Given this list of marker genes ADH1A, LGALS4, PPP5C, PPP2R5C, LPIN1, RTF1, BYSL, ICA1, COMT, RPL36AL, SPARC, SLC4A1, DNTTIP2, TOP1, SLC25A46, WT1, ERF, MSH3, RARRES2, DRD3, TAF4, PSKH1, MAN2A2, UBB, EIF2S1, MARK3, R3HDM1, MAPK14, RPS7, ATP5F1A, ZNF274, TMSB4X (NCBI Gene Id 7114), FKBP1B, TPM1, PIGF, MED24, POLR2G, UQCRH, KRIT1, RPS25, SERINC3 (NCBI Gene Id 10955), LNPEP, ALDH9A1, RPS18, PSMA6, SFSWAP, MED12, QARS1, CITED1, ELL2, SEC14L1, CKMT2, RPL31, DPP4, MUC2, BCL2L2, NDUFV2, UBE2D2, RBBP6, TFPI2, RARS1, DYNLT1 (NCBI Gene Id 6993), PABPC4, SLC2A3, SLC6A3, POLR2F, GNB1, HOXC5, HADH, IFI16, MARCHF6, BLM, MDH1, RBMY1A1, ZMYND8, TOP3A, CDH13, LGALS3, IGFBP5, VLDLR, H2BC21, LAMC1, CASP4, CTSH, UGP2, SNX1, HPD, MAPK6, IRX5, NEU1, TMSB10, ATP5MC3, MPI, SDHB, HMGN4, ATP5PF, COX8A, ACP1, CDC16, EGFR, NFKB1, EXOSC7, AIMP1, MERTK (NCBI Gene Id 10461), PON2, ATP5F1C, GTF3C2, KLK6, CFP, VDAC2, COX6A1, FH, MARF1, SNRPD3, DNTT, CD1D, SOD2, ELOC, NIPA2, IMPDH1, PTGR1, PARG, MATN1, SURF1, here is a description of the gene set: Human Gene Set: KAYO_AGING_MUSCLE_DN In laboratory rodents, caloric restriction (CR) retards several age-dependent physiological and biochemical changes in skeletal muscle, including increased steady-state levels of oxidative damage to lipids, DNA, and proteins. We have previously used high-density oligonucleotide arrays to show that CR can prevent or delay most of the major age-related transcriptional alterations in the gastrocnemius muscle of C57BL/6 mice. Here we report the effects of aging and adult-onset CR on the gene expression profile of genes in the vastus lateralis muscle from rhesus monkeys. Gene expression analysis of aged rhesus monkeys (mean age of 26 years) was compared with that of young animals (mean age of 8 years). Aging resulted in a selective up-regulation of transcripts involved in inflammation and oxidative stress, and a down-regulation of genes involved in mitochondrial electron transport and oxidative phosphorylation. Middle-aged monkeys (mean age of 20 years) subjected to CR since early adulthood (mean age of 11 years) were studied to determine the gene expression profile induced by CR. CR resulted in an up-regulation of cytoskeletal protein-encoding genes, and also a decrease in the expression of genes involved in mitochondrial bioenergetics. Surprisingly, we did not observe any evidence for an inhibitory effect of adult-onset CR on age-related changes in gene expression. These results indicate that the induction of an oxidative stress-induced transcriptional response may be a common feature of aging in skeletal muscle of rodents and primates, but the extent to which CR modifies these responses may be species-specific. studied in species Homo sapiens from publication Kayo T, Allison DB, Weindruch R, Prolla TA (PMID 11309484) Downregulated in the vastus lateralis muscle of aged vs young adult rhesus monkeys